The following is a description of a gene set: species: Homo sapiens The activation signaling of transcription factor nuclear factor-kB (NF-kB) plays central role for immune system. One of key kinase mediating this pathway is TAK1 in adaptive and innate immunity. However, role of TAK1 in B cell receptor signaling is still unclear. To know effects of TAK1-deletion on the gene expression induced by anti-IgM, we performed the time course analysis in comparison of wild type with TAK1-deleted splenic B cells. Human Gene Set: GSE41176_WT_VS_TAK1_KO_ANTI_IGM_STIM_BCELL_1H_UP Genes up-regulated in B lymphocytes treated by anti IgM for 1h: wildtype versus MAP3K7 knockout. from publication Shinohara H, Behar M, Inoue K, Hiroshima M, Yasuda T, Nagashima T, Kimura S, Sanjo H, Maeda S, Yumoto N, Ki S, Akira S, Sako Y, Hoffmann A, Kurosaki T, Okada-Hatakeyama M (PMID 24833394), and this is the list of marker genes: MYLK3, THOC2, GRIA1, DCUN1D3, ALKBH2, GTF2IRD2, CASP2, VEPH1, DNAJC30, NGEF, TSPY1, GPN1, ZFAT, CDH23, TNFSF14, MT1E, THBD, A4GNT, XKRX, BICD2 (NCBI Gene Id 23299), SH2D4B, SERBP1, LINC01973, CAMK2N2, TFAP2D, GJD2, PRDM16, MARK3, SAMD5 (sterile alpha motif domain containing 5), FANK1, ANKRD26, SLC35D3 (NCBI Gene Id 387073), SLC10A2, TOR3A, LMAN1, RPAP2, DNAJC3, L1TD1, POLE4, PDAP1, SLC4A9, NR6A1, LRRC74A (NCBI Gene Id 145497), SPNS3 (NCBI Gene Id 201305), DNAH8, ABCA8, RBSN, PTDSS1, C3orf22, TBCE, INHA, SATB1, ZBTB40, FRAT2, PCDHB13, CELA2A, ST14, INSYN2B, GCNT3, GADD45G, MEAF6, TSPAN8, ZFP2, B3GAT2, LRRTM2, POLR1F, CLCA4, UCN3, LMOD1, KCNC4, ZC2HC1C, FBXO15, TTLL3, RND1, INPP5E, STK24, GP1BA, MT2A, NADSYN1, SBNO2, PRKG1, MET, ARHGEF10L, UNKL, ANP32B, RIC3, TAF4, MAP3K8, HEPH, TERF1, SLC6A14, ARFGAP1, NFIL3, MOXD1, CCDC106, CALB1, RUVBL1, STAC, AGR3, NFAT5, SZT2, PHACTR4, PPIB, RNF43, KRT2, SRRD, TRIM7, SUN3, SNRPF, NPM3 (nucleophosmin/nucleoplasmin 3), CCNYL1, SPMIP4, YES1, RALY, HECTD4, MGAT4C, PEBP1, PROZ (protein Z, vitamin K dependent plasma glycoprotein), SCARA3, ABL1, GPRC5A, RIOK1, IER3, EIF4G3, WDR13, WDR70, JCHAIN, MCAT, LRIT1, ADRB1, ALX1, TDP1, NBEA, TNFRSF18, CCDC150, UBE3D, SNAP47, CRISP3, TRAPPC9, UBXN4, UBQLN3, TFAM (NCBI Gene Id 8033), NCKAP1L, UBQLN2, ST6GAL1, ALKBH8, CEP126, MISFA, TBL1XR1, CHST10, PROS1, TRIM29, EBF2, ENTPD7, SDAD1, MAU2, ADAMTS20, SCLT1, VNN1 (vanin 1), TMEM260, SYCE1L, HORMAD1, SRSF12, MORC4, LRRC28, SMARCA1 (SWI/SNF related, matrix associated, actin dependent regulator of chromatin, subfamily a, member 1), LONP1, ZNF423, SFTPC, KDELR2, FBLN7, DET1, CSGALNACT1, CREB5, RAB3GAP1, IL10, SS18 (SS18 subunit of BAF chromatin remodeling complex), GCGR, DHX57, EBF3, UCN2, LDHD, ZYX, CSNK2A1, VCPIP1, PPP4R4, ANAPC4, ZBTB37, GRHL1, ZNF169, IRF1, AGRN, PDCD6IP, PTGFRN, ZFYVE9, SOCS3, UTP23, PPP1R17